The following is a description of a gene set: Mouse Gene Set: MIR_26B_5P Genes predicted to be targets of miRBase v22 microRNA mmu_miR_26b_5p in miRDB v6.0 with MirTarget v4 prediction scores > 80 (high confidence targets). from publication Chen Y, Wang X (PMID 31504780) studied in species Mus musculus, and this is the list of marker genes: Tbc1d30, Hoxd13, Car13, Clec14a, Crebrf, Faim, Mmp16, Taok1, Pdhx, Gata5, Ube2h, Mab21l1, Fa2h, Rb1, Gna13, Pcnp, Cdk8, Ttpa, Rcn2, Zfp148, Kmt5a, Cebpz, Wnk3, Ep300, Col22a1, Tnrc6a, Stx3, Mtfmt, Nabp1, Slc45a4, Atp11c, Clgn, Twf1, Pmepa1, Ssh2, Palm3, Hoxa9, Eif5, Asxl1, Tnrc6b, Relch, Cep68, Mfhas1, Fbxo48, Sox5, Mtdh, Pcm1, Dcaf7 (DDB1 and CUL4 associated factor 7), Rhoq, Msantd1, Tob1, Scaper, Ubn2, Slc30a5, Natd1, Mme, Rps6ka6, Dock4, Epha2, Itprid2, Srgap1, Bak1, Hexim1, Dyrk1a, Zfp275, Sbno1, Slc1a1, Catspere2, Jag1, Nup50, Zbtb18, Gad2, Pom121, Trpc4, Rgs4, Etf1, E2f7, Tmem248, Slc38a6, Klhl42, Gmds, Frat2 (frequently rearranged in advanced T cell lymphomas 2, NCBI Gene Id 212398), Togaram1, Senp5, Zfp410, Ube4b, Fam136a, Hectd3, Kcnq4, Trim37 (tripartite motif-containing 37), Slc38a2, Ice1, Gsk3b, Mex3c, Zfp462, Htr1a, Snn, Mras, Mical3, Homer1, Pten, Abi2, Slc25a20, Crebzf, 2510039O18Rik, Dmxl1, Rnf6, Camsap1, Ints2, AU040320, Sft2d3, Usp3, Ergic2, Bloc1s2, Bod1, Tab3, Cfap43, Usp25, Pcnx1, Abhd17b (NCBI Gene Id 70566), Fhip1a, Bcr, Ghsr, Arpp21, Eif4g2, Zfc3h1 (zinc finger, C3H1-type containing), Rassf3, Wnk1, Hoxc4, Acsl3, Cacna1c, Suz12, Ddx3x, Tet3 (tet methylcytosine dioxygenase 3), Rbm24, Adam9, Tbc1d4, Prkcq, Hpgd, Arpp19, Ep400, Ccne2, B4galt4, Plp1, Baz2b, Prkcd, Cd200, Abhd18, Cep350, Zfp518a, Tlr3, Ark2n, Lsm12, Fam222b, Ppp3r1, Frmd4b, Epc1, Elavl2, Ccn2, Celsr1, Tppp (tubulin polymerization promoting protein), Rspry1 (ring finger and SPRY domain containing 1), Ccnjl, Anks1b, Mark1, Ap1s3, Skp2, Ythdf3, Onecut2, Tanc2, Ctnnd2, Vdac1, Lyve1, Stradb, Ankrd63, Reep4, Dcdc2a, Adamts6, Srp19, Esp36, Csnk1g1, Gm5114, Zdhhc18, Slc2a13, Cdk6, Tet2, Pitpnc1, Pcdh9, Sema6d, 1700006A11Rik, Styx, Resf1, Nudt11, Zdhhc20, Strbp (spermatid perinuclear RNA binding protein), Arhgef10, Rap2c, Thnsl1, Fbxo11, Serbp1, Loxl2, Jarid2, Zswim6, Mfn1, Clasp2, Chac1, Rpgr, Abcc4, Ccnj, Map3k9, Spred2 (NCBI Gene Id 97717), Mdn1, Plod2, Psd3, Inhbb, Hoxd8, Map10, Nus1, Slc19a2, Mtm1, Ube2e2, Mex3b (NCBI Gene Id 93845), Il20 (NCBI Gene Id 58181), Rps6ka2, Arhgap21, Adam19, Depdc1b, Eif2s1, Zfp175 (NCBI Gene Id 210104), Dmrt3, Bhlhe40, Tmcc1, Tmem68, Adam23, Dennd4a, Matr3, Col1a2, Map2, Chd2, Adam17, Sar1b, Lnx2, Ubr3, Ube2j1, Amot, Aspn, Sfmbt2 (NCBI Gene Id 353282), Chfr, Fam53b, Hsbp1, Serpinb9b, Peli2, Greb1l, Carmil1, Cttnbp2nl, Zdhhc6, Dapk1, Nab1, Trp53inp1, Rgs17, Gm5592 (NCBI Gene Id 434172), Tfap2a (transcription factor AP-2, alpha), Col10a1, Rest, Ppp3cb, Tub, Rcbtb1, Grk2, Aldh5a1, Man2a1, Acbd5, Epb41l3, Capn10, Rgs6, Hephl1, Stk39, D030056L22Rik, Galnt7, Phf20l1, Ndfip2, Larp1, Dab2, Pawr, Casz1, Trappc6b, Fbxo28, Pfkfb3, Trpc3, Ulk1, Arb2a, Thap2, Nampt, Adm, Atad2b, Rpl37, Abl2, Otud4, Nagpa, Pja2, Gmfb, Col19a1, Chic1, Mfsd6, Acvr1c, Tmem184b, Magi3, Erc2, Fgd1, Tigd4, Slc7a11, Tsc22d2, Kpna2, Bag4 (NCBI Gene Id 67384), Ptpn2, Car12, Dlg5, Ctsl, Smad1, Ypel1, Fam98a (NCBI Gene Id 72722), Tmx1, Ttc13, Kpna6, Chd1 (NCBI Gene Id 75119), Tet1, Cipc, Abhd5, Pwwp3b, Phf6, Prr5l (NCBI Gene Id 74608), Arhgef26, Or13c7c, Palmd, Pak2, Ddx17, Zfp608, Mxi1, Cnot6l, Nap1l5, Zfp711, Cemip2 (NCBI Gene Id 83921), Sh3rf1, Kctd18, Ugt8a, Mfsd14a, Grb10, Stac2, Bcl7b, Phldb2, Atf2, Ssx2ip, Abca5, Tpsb2, Gpsm1, Bfar, Pcdh18, Ulk2, Grhl3, Pdcd10, Osbpl11, Pgrmc2, Zfhx4, Mapk6, Ppp1r15b, Gm4884, Il36b, Plcb1, Slc22a23, Ezh2, Zcchc24, Siae (NCBI Gene Id 22619), Ttpal, Mier3, Slc25a16, Trib2, Tmed2, Anks1, Srcap, Fbxl19, Tmc7, Epc2, Ccdc6, Dnmt3a, Plekhh1, Vangl2, Hgf, Tnrc6c, Hmga1 (high mobility group AT-hook 1), Dnajc21, Arl4a, Mat2a, Cpsf2, Tmem41b, Nceh1, Itga5, Ube2g1, Clic5, Usp9x, Armcx2, Nfe2l3 (nuclear factor, erythroid derived 2, like 3), App, Ptgs2, Naa15, Kbtbd8, Il6, Pik3r3, Pfdn4, Pdgfra, Kcnj2, Tmc8, St8sia4, Adamts20, Cdk2ap1, Mtx2 (metaxin 2), Eri2, Parp10, Dennd1b